Given this list of marker genes Siglecl2, Arpc2, Mgat4c, Runx1t1, Chek2, Zbtb8a, Mettl13, Ctsc, Cd81, Wdr37, Hsd17b12, Ppfibp2, Kif5a, Sp1, Kcne1, Ubxn7, Nhsl2, Trank1, Calcoco1, Trps1, Jph1, Tafa1, Serpinb8, Tmem135, Pik3r1, Aqp7, Slc30a7, Trmt11, Smarca1, Tmem175, Odaph, C1s1, Nlrp10, Prkaca (protein kinase, cAMP dependent, catalytic, alpha), Wfdc13, Col5a3, Pdk4, D630039A03Rik, D430041D05Rik, Mob1b, Man1c1, Zfp329, Lrrc8d, Pals2, Pramel16, Zfp423, Daglb, Prkg1, S2bpcox16, Dlgap1, Wdr36, Bcl11a, Zfp719, Lix1, Src, Atf2, Kpna6, Trp53inp2, Kank2, Insl5, Gabarapl2, Dis3l, Gykl1, Pdlim5, Cramp1, Dusp10, Shank1, Neurod4, Neurl1b, Alyreffm14, Golim4, Jazf1, Tmem71, Steep1, Deptor, Hsdl1, Spock3, Camta1, Ror1 (receptor tyrosine kinase-like orphan receptor 1), Pcyox1, Igfbp4, Eif2s1 (NCBI Gene Id 76274), Ptges3, Rap2c, Apba1, Slc35d1, Jdp2, Tbr1, Bloc1s6, Ovgp1 (oviductal glycoprotein 1), Asb7, Pcdhb16, Dip2c, Noa1, Oxsr1, Zbtb16, Thbs1, Capza2, Atg4c, Mycs, Sipa1l3, Crisp3, Cab39, Ikzf2, Myoz3, Phex, Vwa7, Zfp395, Pax3, Rnf150, Pak2, Mier3, 9530068E07Rik (NCBI Gene Id 97739), Ints7, Sec14l1, Prrg1, Hnrnpu, Glra2, Alyreffm13, Ankrd17 (ankyrin repeat domain 17), Eea1, Magi1, Dsg1b, Btg1, Psd3, Rbm4b, Utrn, Marcks, Abcc1, Thsd7a, Mtx2, Mlkl, Kdm5d, Plekha3, Cps1, Tex50, Prdm9, Celf1 (CUGBP, Elav-like family member 1), Ino80d, Osbp2, Hoxc13, Rbms3, Timp1, Cenpl, Dpys, Sdk1, Cd274, Dync1li2, Cpeb1, Tcf7l2, Cd3e, Epm2aip1, Sox8, Atp6v0e, Actbl2, Clec4e, Prdm4, Cxcl14, Ids, Immp1l, Sbk3, Cox11, Erbb4, Ldb3, Serpinh1, Kctd6, Mgat4a, Gsx1, Hsd17b6, Ldb2, Unc5c, St6galnac3, Uqcrc2, Stxbp6, Septin3, Mbnl1, Gm13040, Camk2d, Alyreffm11, Icmt, Tenm3, Arid4a, Cox16, Pde4b, Cpox, Cdh11, Ptbp2, Fry (FRY microtubule binding protein), Baz2a, Slc4a7, Ankmy2 (NCBI Gene Id 217473), Rbbp4, Smad6 (SMAD family member 6), Sh3gl1, Pik3c2b, Dad1 (NCBI Gene Id 13135), Rtn4rl1, Usp46, Dtwd2 (NCBI Gene Id 68857), Pax9, Slc22a3, Thoc2, Garre1, Igf2bp2, Foxn3, Fut9, Sdc1, Erc2, Nrxn2, Zfp442, Nsun6, Zfp711, Tmco1 (NCBI Gene Id 98577), Scn2b, Usp15 (ubiquitin specific peptidase 15), Pbx1, Tcf21, B3galt1, Itpripl2, Dapk1, Fam98a, Ormdl3, Nqo1, Mcc, Afap1l2, Zfp275, Cflar, Chp1, Tmtc3, Dcaf12l2, Yipf5, Bdp1, Dynlt1a, Nup205, Farp1 (FERM, ARH/RhoGEF and pleckstrin domain protein 1), Dcdc2a, Dhodh, Foxp1, Bclaf3, Trim35, Knstrn, Gtpbp10, St8sia1, Lrrn2, Spin1, Elavl1 (ELAV like RNA binding protein 1), Zfp318, Carf, Efcab14, Chd9, Frmd6, Terb2, Gfpt1, Dynlt1c, Krtap15-1, Kdelr2, Mn1, Mylk4, Epb41l2, Trmt10a, Bmp2, Glul, Barhl2, Wipf2, Pcmtd1, Aff1 (NCBI Gene Id 57071), Alyreffm10, Lgi2, Insr, Alcam, M6pr, Gm13057 (predicted gene 13057), Ncapd3, Prickle2, Npas3, Pnma2, Adam23, Cntn4, Fshr, Tshz3, Fgf9, Ostn, Gtdc1, Ppip5k2, Ano4, Fam199x, Zfp827, Tet1, Col11a1, Dynlt1b, Pramel31, Tnfrsf21, Wdr48 (NCBI Gene Id 67561), Pappa, Akap13, Rp1, Pate9, Slc35e1, Ext1, Arl6ip6, Gas6, Cacna1e (calcium channel, voltage-dependent, R type, alpha 1E subunit), Pls3 (plastin 3 (T-isoform)), Arf5, Ywhab, Acsf2, Lratd2, Cd109, Cadm3, Arap2, Khdrbs3, St18, Rasgrp1, Grin2b, Ikzf1, Fhip1b, Ulk3 (unc-51-like kinase 3), Ccdc82, Lrp3, Zfp831 (zinc finger protein 831), Nol4, Robo2, Tspan10, Phf21a, Bptf, Tspan5, Gucy1a2, Itga6, Sdf4, Spidr, Igsf11, Phf13, Fam76a, Tent4b, Mtf2, Mettl9, Gldn, Scai, Snx16, Zfp36l1, Ppp1r17, Mfap1b, Rbfox3, Dusp7, Mtcl2, Pramel20, Ntn1 (NCBI Gene Id 276903), Nr4a3, Syt4, Taf2, 2510039O18Rik, Vps37a, Commd8, Slc49a4, Chl1, Zfp617, Fzd3, Phf2, Dynlt1f, Celf5, Nfia, Ctnna2, Nipbl, Cmtm4, Znrf2, Cpsf6, Lmo2, Ipmk (inositol polyphosphate multikinase), C5ar2, Mga, Mfsd14b, Mtss1, Pou2f1, Hoxa5, Coro1c, Esm1 (endothelial cell-specific molecule 1), Slk, Ankfy1, Gpc6, Bach2, Pde2a, Cdkn2d, Ash1l, Snhg11, Sel1l, Atl2, Klhl2, Rarb, Itgb6, Suclg2, Dido1, Mapk4, Tead1, Alyreffm15, Clgn, Pdzd2, Kcnma1, Tubb2a, Ebf1, Dck, Sema4d, Tra2b, Rassf5, Dyrk1a, Esr1, 0610030E20Rik, Pik3c2a, Mkx, Rfx3, Satb2, Frg1, Sec22a, Ano1, Ubtf, Zfyve26, Sox9, App, Homez, Sidt1, Gmds, Stox2, Timmdc1, Cntnap5b, Ebf2, Eps15l1 (epidermal growth factor receptor pathway substrate 15-like 1), Mtpn, Dcx, Lsm12, Zfp879, Lef1 (NCBI Gene Id 99641), Or2ag2b, Opcml, Aco1, Rc3h2, Tmem231, Klhl15, Cacnb1, Ppp4r3a, Gpatch2l, Kcnb1, Kmt2a, Exoc3, Kcna1 (potassium voltage-gated channel, shaker-related subfamily, member 1), Gpr149, Csnk2a1, Ifi209, Alyreffm16, Pbx2, Crisp1, Itpripl1, Pcdhb18, Kdm7a, Map3k2, Gabrb2, N4bp2l1, Abca15, Itk, Cpeb4, Wnt3a, Fbxo11, Galnt3, Slitrk2, Mllt3 (myeloid/lymphoid or mixed-lineage leukemia; translocated to, 3), Tcf12, Tle1, Ypel5, Slc38a9, Borcs7, Phka1, Rhoa, Sfxn3, Ogfod1, Gng7, Sh3glb1, Clec5a, Mllt11, Synj2bp, Elapor2, Zfp458, Zscan25, Mmp16, Sult4a1, Gskip, Ssbp2, C1s2 (NCBI Gene Id 317677), Tapt1 (transmembrane anterior posterior transformation 1), Nin, Ipo11, Uvssa, Nrxn3, Slc14a1, Ddn, Spon1, Mei4, Gm13043, Riok3, Zc3hav1l, Krtap4-1 (NCBI Gene Id 670335), Gfm2, Ern1, Ahnak, Atxn1, Rufy2, Car5b, Cdv3 (carnitine deficiency-associated gene expressed in ventricle 3), Ncoa2, Pou2af1, Rbm24, Lrrc58, Nufip2, Onecut2, Cnbp, Gnrhr, Ank3, Alyreffm17 (Aly/REF export factor family member 17), Pja2, Ubfd1, Arhgef26, Grm5, Ak1, Lratd1, Tor1aip2, Pdcd4, Creb5, Epha5, Plekho2, Kdm6a, Nucks1, Zmat3, Snx15 (sorting nexin 15), Klhl36, Igf2bp1, Actr3, Zc4h2, Scd1, here is a description of the gene set: Genes predicted to be targets of miRBase v22 microRNA mmu_miR_7661_5p in miRDB v6.0 with MirTarget v4 prediction scores > 80 (high confidence targets). species: Mus musculus Mouse Gene Set: MIR_7661_5P from publication Chen Y, Wang X (PMID 31504780)